The following is a description of a gene set: Human Gene Set: GOBP_NEGATIVE_REGULATION_OF_NUCLEOTIDE_BIOSYNTHETIC_PROCESS studied in species Homo sapiens Any process that stops, prevents, or reduces the frequency, rate or extent of the chemical reactions and pathways resulting in the formation of nucleotides., and this is the list of marker genes: PARP1, PID1, RD3, MIR675, ATP5IF1